Given this list of marker genes Csf1, Mir875, Fgf8, Ift88, Ngfr, Dicer1, Wnt10a, Runx2, Bmp4, Rspo2, Apcdd1, Dmrt3, Bmp2, Prkcb, Tnfrsf11b, here is a description of the gene set: studied in species Mus musculus Any process that modulates the frequency, rate or extent of the formation and development of teeth, the hard, bony appendages which are borne on the jaws, or on other bones in the walls of the mouth or pharynx of most vertebrates. Mouse Gene Set: GOBP_REGULATION_OF_ODONTOGENESIS_OF_DENTIN_CONTAINING_TOOTH